Given this list of marker genes PSMA8, CDC14A, SNTB2, SLITRK4, SLC35A5, STC1, TSC22D2, HAND1, TLL1, PTPN11 (protein tyrosine phosphatase non-receptor type 11), ZFP36L1, MBD4, FBXW7, MDH2, CDK1, CYSLTR1, TFE3, MRS2, PROX1 (NCBI Gene Id 5629), PCDH8, SMARCA2, JAZF1, CNOT8 (NCBI Gene Id 9337), ARG1, SCOC, RNF11, EPHX2, CLOCK, TNPO1, ZNF568, DEUP1, UBE2N, SLCO1A2, MAP3K2, CTHRC1, TNRC6C, GUCY2C, UTY, EYA4, HIC2 (HIC ZBTB transcriptional repressor 2), HMGN3, MDK, CD83, KRR1, TSEN34, RALYL, VSIG10, UBE2B, ENOSF1, CCNYL1, RAB11FIP2, DEGS1, CCDC126, MAP4K5, TC2N, LYN, MAP3K21, ZKSCAN1, ZNF781, ZNF280D, GNAI3, NMBR, PRKRA, SDE2, ZNF483, AK4, AP5M1, SIRT1, SPARC, MMP19, JAKMIP3, ALDH1L2 (NCBI Gene Id 160428), GPD1L (NCBI Gene Id 23171), KAT6B, SLC17A6, ARID4B, AK7, ZNF704, ABHD18, SSX2IP, SMC2 (NCBI Gene Id 10592), PPP3CA, ZNF507 (NCBI Gene Id 22847), DSCAM, PLPP3, GABRB2, GPRC5B, ZNF823, WEE2, PLAC9, ZFR, TRA2A, USP13, MBLAC2, ROCK2, HNRNPA2B1, RNF111, NOG, TET1, SERP1, PDIK1L, NR3C1 (NCBI Gene Id 389335), GABRA1 (gamma-aminobutyric acid type A receptor subunit alpha1), HDAC9, SLC25A43, USP47, MDN1, PGD, ADCY3, UNC80, STXBP1, RPS6KA6, PAIP2 (poly(A) binding protein interacting protein 2), DCN, NEDD1, ZNF280C, DAB2, ODR4, MSI2, GLCCI1, ANK2, ZNF799, DSN1, MARCHF4, SAMD4A, CTXN1, PTK2, GUCY1A1, TMEM170B, RECK, AFF4, CCDC66, CRBN, CDC73, RNF149, RNF38, JMJD1C, EIF5, DENND1B, ABCG1, C8orf44-SGK3, RAPGEF6, MTF1, MFAP3L, ADORA3, HNF4G, ME1, NT5C1B-RDH14, JAM3, DTHD1, CCNJ, UFC1, GLS, FAM120B, FGFR1OP2 (NCBI Gene Id 378428), ING4, MXI1 (NCBI Gene Id 4601), TLCD4, PRXL2C, FAM107B, STARD4, FUT9, SPDYA, AFAP1, PIK3R1, RHOQ, FREM2, CTNND2, ZDBF2, STC2, ADCY1, PRRC1, MFAP3, TTC1, ST8SIA4, CNIH4, MTHFD2L, RFWD3, TLE3, SLC12A6, PPHLN1, ITGB8, TOR1AIP1, CUL4A, CERT1, ADAM23, SPRY3, MTM1, ZBTB20, LATS1, SUZ12, UBE2K, ITGA2, REXO2, ADGRA2, CLTC, PECR, GRIK2, PDS5B, VPS13A, SMARCA1, TIMM8A, ZNF816-ZNF321P, ACSL4, KCNQ3 (NCBI Gene Id 3786), AQP4, STAG1, CDR2, PKNOX1, FERRY3, SYCP2, ZMYND11, HMGN2, CPEB2, TBX18, SNX3, ZBTB43, NUFIP2, NEFL, HOXC4, XPO5, KCNV1, ARRDC5, MBD2, PTPRE, CNTN4, TRAPPC13, PHF20L1, KLHL41, ADAMTSL3, FHIP2A, SKP2, SASH1, LONRF1, G2E3, SRPK2, RORA, SLK, NEUROD6, SMAD2, TENT2, ZNRF3, SGK3, FAM118B, ZNF443, AGTR2, ABTB3, KIAA1549, GRP, MRPS28, SMIM17, GTPBP10, TPST1, TCF15, SLC44A1, here is a description of the gene set: Human Gene Set: MIR208A_5P studied in species Homo sapiens from publication Chen Y, Wang X (PMID 31504780) Genes predicted to be targets of miRBase v22 microRNA hsa-miR-208a-5p in miRDB v6.0 with MirTarget v4 prediction scores > 80 (high confidence targets).